The following is a description of a gene set: from publication Chen Y, Wang X (PMID 31504780) Human Gene Set: MIR6516_5P Genes predicted to be targets of miRBase v22 microRNA hsa-miR-6516-5p in miRDB v6.0 with MirTarget v4 prediction scores > 80 (high confidence targets). species: Homo sapiens, and this is the list of marker genes: THEM4, DENND1B, TPT1, CSMD3 (CUB and Sushi multiple domains 3), ABL2, PRND, ZNF268, APIP, MAN1A1, HOOK3, NUP58, SLC35E3, TENT4B, SCOC, SLC35F1, CHIC1, RTN1, REV3L, PCDH9, MAP3K13, CHEK1, KIF16B, SLC6A15, SCGB2A1, KERA, ASPHD2, G3BP2 (G3BP stress granule assembly factor 2), SLC9A7, ADNP, SSBP2, DTNA, ARPC5, KPNA1, NEUROD1 (NCBI Gene Id 7853), STK39, ROCK1, GOLM2, ZFP36L1, NHS, FANCA, GNAI2, ITCH, DIPK1A, TIMELESS, OTOR, SMS, CEP44, GPATCH2 (G-patch domain containing 2), FEM1C, BCL7A, GRIA1, ADCY2, FUT4, NPAT (nuclear protein, coactivator of histone transcription), CLDN12, GDI2, ADAM22, TNKS2, CNIH2, ASB7, POU2F1, USP25, HIPK3, LRRC15, CSNK1G3, SH3PXD2A, LRRN1, PDLIM5, CGGBP1 (CGG triplet repeat binding protein 1), EIF6, ABCE1, PAIP1, GUCD1 (NCBI Gene Id 83606), IGF2BP2, EIF4G3, SLC12A6, BAALC, CCDC148, ASCL1, AGTPBP1, ATXN7L1, BCLAF1, XDH, RAD50, UCP3, ICMT, BICRAL, MYOZ2, COMMD10, STK38L, CDIN1, RGL1, SIAH1, LSM8, CAPRIN1, ZNF106, NRG1, LAMA5, CHD6, PRKCE, DUSP19, CFAP97, NUP160, PIEZO2, PTGER3, ZNF480, ANK3, SCAI, ARF6, ASAP1, IRF2BPL, KLHL11, ARHGEF2, IQCK, MDGA1, TEX9, MVB12B, ZNF304, PLAGL1, FBXL2, MITF, TMPO, ATP2B4, XPO4, MALT1 (NCBI Gene Id 10892), GNAL, NTNG1, USP9X (ubiquitin specific peptidase 9 X-linked), SFXN3, CAMK1D, LARP4B, ATP8A1, PTPMT1, WIPF3, DCBLD2, TRAF3, SLAMF7, ZNF385D, CORIN, SLFN5, FAM170B, TPP2, CD164, PF4V1, CCN1, FASTKD5, PANK3, ST3GAL6, KLF3 (NCBI Gene Id 51274), CX3CR1, IREB2, ENTHD1, THAP9, PABPC1L, SHANK2, BRCA1, RAB10, INSYN1, GOLIM4, CRIPT, PWWP2A, ATG14, FBXW2, ANKRD12, AAK1, ETS2, FLRT3, GLP2R, NDRG4, PDS5A, ITGA6, PDK1, CHM, C6orf120, ADGRL2, TENT5A, RARRES1, BBX, SEC31A, PRMT2, FCGR1BP, OPN5, INSIG2, SGIP1, ATF1, ARPP21, ADGRE3, ELK3